The following is a description of a gene set: Leucine-rich repeat flightless-interacting protein 1 (LRRFIP1) can bind exogenous double-stranded RNA and double-stranded DNA (Wilson SA et al. 1998; Yang P et al. 2010). LRRFIP1 was shown to mediate Listeria monocytogenes- and vesicular stomatitis virus (VSV)-induced IFN-beta production in mouse primary macrophages by regulating beta-catenin activity. Beta-catenin possibly functions as a transcriptional cofactor of IRF3 to initiate Ifnb1 transcription (Yang P et al. 2010). part of: Cytosolic sensors of pathogen-associated DNA  Reactome Pathway: LRR FLII-interacting protein 1 (LRRFIP1) activates type I IFN production studied in species Homo sapiens, and this is the list of marker genes: LRRFIP1, CTNNB1, IRF3, CREBBP, EP300